Given this list of marker genes Cpeb2 (cytoplasmic polyadenylation element binding protein 2), Nme1, Abce1, Pim1 (proviral integration site 1), Mtif2, Eif4h, Mtif3, Eif1b (eukaryotic translation initiation factor 1B), G3bp1, Eif1, Eral1, Ptcd3, Ddx3x, Usp16, D1Pas1, Npm1, Larp1, Dhx29, Eif4b, Mcts1 (malignant T cell amplified sequence 1), Ung, here is a description of the gene set: Binding to a small ribosomal subunit. species: Mus musculus Mouse Gene Set: GOMF_RIBOSOMAL_SMALL_SUBUNIT_BINDING